Given this list of marker genes NOTCH2NLA, FGF23, TRDMT1, SKA3, ZDHHC20, CCNC, TMEM41B, RCOR3, C8orf34, UBE4B, FBXO3, MMAA, UBE2B, MAPK10, P4HA3, CYCS, RNF180, FAM3C, IFRD2, BRWD3, EIF3A, SRGN, SRSF1, NUP155, LSM14A, USP38, HOXD3, IRAK1BP1, LAMA3, SCN3A, DENND6A, SMIM8, VLDLR, MAPK6, RFESD (Rieske Fe-S domain containing), RAPGEF4, RNF2, MAB21L1, DNAJB14, TCEA1, SHOC2, SPATS2L, CD38, LTN1, ZNF641, TMEM47, LRP1B, ZNF451, PTPRD, SUB1, DACH1, CPSF6, SLC9C2, GRID2, CROT, MAPKAPK3, SPTLC2, HAS2 (NCBI Gene Id 3037), CAND1, TRA2B, CADM2, NLRP11, SATB2, U2SURP, ZNF175, ZNF718, XRN1, CCSER2, BIRC2, SCP2, TMEM170B, RBMS3, DNAJB6, ZBTB41, USP49, RDH11, DESI2, NOVA2, CFAP57, IL18BP, MFSD13A, PAK3, SIK3, LINC02909 (NCBI Gene Id 196415), ZNF805, VASH2 (vasohibin 2), TAF5L, PPP4R1, CHD1, SEMA3E, PEX2, PNN, CNOT1, ADI1, RDX, SOX11, BAMBI, AZIN1, AMFR (NCBI Gene Id 267), C9orf40, PINX1, TEKT3, ST6GALNAC3, LINC02898, ZNF274, ZNF514, TBL1XR1, SPOPL (NCBI Gene Id 339745), NFE2L2, AKIRIN2, UBE2L3, IL10RA, ARF6, ZSCAN20, GABRB2, CHIC2, MACROD2, SERBP1, FGD4, LEKR1, FAXC, RPS6KB1, KRR1, TXNRD1, TM9SF1, PUS3 (pseudouridine synthase 3), TTLL2, PCOLCE2, TMBIM4, UBE3A, ZBTB34, SNX13, SOX4 (NCBI Gene Id 6659), BCL10, PXK, CNOT10, PRKCA, REEP1, HYCC1, ALS2, POLK, ACE2, ODR4, EHBP1, CPEB4 (NCBI Gene Id 80315), SULF1, HDGFL3, BNIP2, LEPROTL1, RPS27L, SLC35A3 (solute carrier family 35 member A3), here is a description of the gene set: Genes predicted to be targets of miRBase v22 microRNA hsa-miR-500a-5p in miRDB v6.0 with MirTarget v4 prediction scores > 80 (high confidence targets). from publication Chen Y, Wang X (PMID 31504780) Human Gene Set: MIR500A_5P species: Homo sapiens